The following is a description of a gene set: studied in species Mus musculus Mouse Gene Set: GOCC_POSTSYNAPTIC_RECYCLING_ENDOSOME A recycling endosome of the postsynapse. In postsynaptic terminals with dendritic spines, it is typically located at the base of a dendritic spine. It is involved in recycling of neurotransmitter receptors to the postsynaptic membrane. In some cases at least, this recycling is activated by postsynaptic signaling and so can play a role in long term potentiation., and this is the list of marker genes: Myo5b, Vps26b, Abhd17a, Snx27, Ap3m1 (adaptor-related protein complex 3, mu 1 subunit), Rab11fip3, Zdhhc2, Rab4a, Stx12, Akap5, Tfrc, Gripap1, Abhd17b, Rab11a